The following is a description of a gene set: from publication Doering TA, Crawford A, Angelosanto JM, Paley MA, Ziegler CG, Wherry EJ (PMID 23159438) During acute viral infections, naïve CD8+ T cells differentiate into effector CD8+ T cells and, after viral control, into memory CD8+ T cells. Memory CD8+ T cells are highly functional, proliferate rapidly upon reinfection and persist long-term without antigen. In contrast, during chronic infections, CD8+ T cells become “exhausted” and have poor effector function, express multiple inhibitory receptors, possess low proliferative capacity, and cannot persist without antigen. To compare the development of functional memory T cells with poorly functional exhausted T cells, we generated longitudinal transcriptional profiles for each. studied in species Homo sapiens Human Gene Set: GSE41867_NAIVE_VS_DAY6_LCMV_EFFECTOR_CD8_TCELL_UP Genes up-regulated in CD8 T cells: naïve versus effectors at day 6., and this is the list of marker genes: DOP1B, SAMHD1, C19orf38, PLAC8, TRIM25, PNP, DOK1, TMEM230 (transmembrane protein 230), CD300LB, UBASH3B, CYRIA, NADK, ORAI1, XDH, ARRDC4, CD68, PAPSS2, TLR2, PDE8A, WLS, QPCT, RGS14, SH3BGRL3, CASZ1, AP2S1, SPIB, LPCAT1, PARP11, SUMO3, NR4A1, CCDC171, TRIP4, GEMIN8, SLC25A11, PLAAT3, ADPRM, PTGS1, TAF12, ACKR2, MED28, GRAMD4, HOPX, ACOT8, MYO7A, PLBD1, MAP4K5, GSDMD, MSR1, DOCK5, UBR4, SLC31A2, RNF213 (NCBI Gene Id 79398), THBS1, SPIC, CD164, PLSCR3, PSMB10, HSD11B1, SH3GLB1, ZNF691, S100A8, PTK2, OCIAD2, KATNA1, PLXNC1, FBXO33, SAMD9L, B3GNT8, SEC24B, YWHAB, LRCH3, RBM43, RCAN1, NIBAN3, PF4, CD40 (NCBI Gene Id 958), WASF2, NLRC5, NFKBIZ, HLX, DSTYK, PHRF1, TMEM106A, CLEC7A, VDAC2, AMN1, MFHAS1, TRMT1L, ABHD17B (NCBI Gene Id 51104), DTX1, MAP4K3, ITGA6, ENPP4 (NCBI Gene Id 57011), ACAP2 (ArfGAP with coiled-coil, ankyrin repeat and PH domains 2), ADGRL2 (adhesion G protein-coupled receptor L2), PSMA4, GPN1, ESYT1, RAB29, HSD17B11, C19orf12, SDHD, LGALS3, TDRD3, ARHGAP4, IL18BP, CA2, DHX34, LAT2, ZBP1 (Z-DNA binding protein 1), PXMP2, PSMC5, PPM1H, JPT1, UTRN, PSMB9, MTF1, CYP4F3, ITGB2, HIVEP2, PTTG1, OSM, CCL19, SUCO, ANKS1A, DTX3L, IFT140, SLC44A2, BCKDHB, HPS6, IFIT1, ARHGAP25, NFKBIA, TWF2, PTRH2, TAP2, IDNK, PLIN2, RASA3, MED12, IFIT2, EBI3, CYFIP1, SS18L1, CNPY3, TAPBP, RABEPK, NAP1L1, CIB1, TBC1D9B, GNS, POMP, GUCD1, LPAR6, ADPRS, PML, ITPKA, PRKCQ, SDHAF4, RASGRP1, PCGF3, ITGA4, IL27RA, KSR1, CNP, GBP6, CLEC4E, BAZ1A, COA5, CXCR3, AGRN, MYL12B, CD86, LLGL1, C1orf54, STK17B, SWAP70, CMTM7, AKR1A1, PPP1R21, CLUAP1, GTF2F1, SVBP, ACOD1, VPS37B, LCMT1, TFEB, CASS4, MYD88, EXTL3, RBX1, ACTB, ACTR1A (actin related protein 1A), HPS3, PDCD4, UBXN2B, SETD6, CFLAR, CTNNA1, TMEM131L